The following is a description of a gene set: Amelogenesis imperfecta Human Gene Set: HP_AMELOGENESIS_IMPERFECTA A developmental dysplasia of the dental enamel. studied in species Homo sapiens, and this is the list of marker genes: SLC24A4, AMBN, DLX3, SMARCD2, DNAJC21, ENAM, TMEM165, LAMA3, FAM20A, PEX1, RELT, AMELX, GPR68, AMTN, ODAPH, CLDN16, SLC10A7, CLDN19, STIM1, ACP4, SATB1, MMP20 (NCBI Gene Id 9313, matrix metallopeptidase 20), ITGB6, WDR72, CNNM4, ORAI1, SP6 (Sp6 transcription factor), PEX6, FAM83H, LTBP3, ROGDI, LAMB3, SLC13A5, KLK4